Given this list of marker genes ACOT7, DCAKD, NUDT19, PPCDC, PANK3, PPCS, VNN1, PANK1, MCCC2 (methylcrotonyl-CoA carboxylase subunit 2), PANK4, NUDT7, ACAT1, CROT, NUDT8, PANK2, ACLY, COASY, HMGCR, here is a description of the gene set: The chemical reactions and pathways involving coenzyme A, 3'-phosphoadenosine-(5')diphospho(4')pantatheine, an acyl carrier in many acylation and acyl-transfer reactions in which the intermediate is a thiol ester. Human Gene Set: GOBP_COENZYME_A_METABOLIC_PROCESS species: Homo sapiens